The following is a description of a gene set: Hematopoiesis, the process by which mature blood cells arise, is controlled by multiple transcription factors, which act in stage- and lineage-specific complexes. It is a major goal to elucidate the genes regulated by these transcription factors, in order to obtain a full understanding of the process and its malignant counterpart, leukemia. Myb family transcription factors play a central role in hematopoiesis. To identify new Myb family target genes, we have used an inducible dominant-negative protein for a subtraction cloning protocol in a model cell system (FDCP-Mix) with many characteristics of normal hematopoiesis. We present here a novel group of 29 validated Myb family target genes of diverse functions. Human Gene Set: LANG_MYB_FAMILY_TARGETS studied in species Mus musculus Myb family target genes. from publication Lang G, White JR, Argent-Katwala MJ, Allinson CG, Weston K (PMID 15608679), and this is the list of marker genes: BET1L, EMILIN2, CCT2, CASP6, NSUN2, CD53, MSN, CBX4, PSD4, TIMM44, ZDHHC21, SET, CLTA, MAD1L1, SLC25A3, IQGAP1, HSPA13, PPP3CA, COPA, HSPA8, FAM107B, TFEC, API5, SEC31A, SLC1A5, TFB1M, SLC20A1, ACTN1, BIRC2